The following is a description of a gene set: species: Mus musculus DeltaFosB (a truncated form of FosB) and CREB (cAMP response element binding protein) are transcription factors induced in the brain's reward pathways after chronic exposure to drugs of abuse. However, their mechanisms of action and the genes they regulate remain unclear. Using microarray analysis in the nucleus accumbens of inducible transgenic mice, we found that CREB and a dominant-negative CREB have opposite effects on gene expression, as do prolonged expression of DeltaFosB and the activator protein-1 (AP-1) antagonist DeltacJun. However, unlike CREB, short-term and prolonged DeltaFosB induction had opposing effects on gene expression. Gene expression induced by short-term DeltaFosB and by CREB was strikingly similar, and both reduced the rewarding effects of cocaine, whereas prolonged DeltaFosB expression increased drug reward. Gene expression after a short cocaine treatment was more dependent on CREB, whereas gene expression after a longer cocaine treatment became increasingly DeltaFosB dependent. These findings help define the molecular functions of CREB and DeltaFosB and identify clusters of genes that contribute to cocaine addiction. Genes up-regulated in the nucleus accumbens (a major reward center in the brain) 8 weeks after induction of CREB1 expression in a transgenic Tet-Off system. Human Gene Set: MCCLUNG_CREB1_TARGETS_UP from publication McClung CA, Nestler EJ (PMID 14566342), and this is the list of marker genes: OLFM1, NDUFC1, BBLN, PTPRD, PCDHA9, BCAT1, AUH, H1-0, HSD17B12, SYT17, TP53INP2, NEUROD6, CERK, STX1A, OCEL1, MOBP, MFSD4A, MEF2C, AQP4, CAP1, SYP, CPLX1, KLF10, CXXC5, CCN3, NR2F1, SIPA1L2, NEUROD2, LAPTM4B, UQCR11, MGST3, NACC2, FBXW7, GLRX3, TMEM14C, CADPS, TMEM160, ASH2L, ELAVL2, NDRG3, GNB1, CDK14, SERF2, RALA, SEMA7A, NEFM, CDH13, ID2, ACYP1, INA, RESP18, UTY, NCBP2AS2 (NCBI Gene Id 152217), STMN1, FSTL1, MPDZ, CCK, FAM9A, FAM3C, DIO2, SERPINI1, TRPC4, BASP1, TTC39B, SYT2, TSPAN5, SCN1B, CCN2, ADCYAP1, CRYL1, STMN2, BZW1, ADARB1, PTGDS, TUBA4A, NPY, SMAP1, SSTR2, PLS3, TUBB3, FABP7, TBR1, OSBPL1A, FGF12, ACKR3, STMN3, FOS, SST, CD59, BDNF, ACOT7, ADCY6, GABRA1, HSPA1B (heat shock protein family A (Hsp70) member 1B), MMP16, IDI1, IFT20, LMNA, HIVEP1 (NCBI Gene Id 3096), SH3GL2, SCHIP1